The following is a description of a gene set: studied in species Homo sapiens Human Gene Set: WP_HEME_BIOSYNTHESIS Heme biosynthesis, and this is the list of marker genes: UROS, CPOX, FECH, HMBS, ALAS2, ALAS1, UROD (NCBI Gene Id 7389), ALAD (NCBI Gene Id 210), PPOX